The following is a description of a gene set: Human Gene Set: GOBP_RESPONSE_TO_METAL_ION studied in species Homo sapiens Any process that results in a change in state or activity of a cell or an organism (in terms of movement, secretion, enzyme production, gene expression, etc.) as a result of a metal ion stimulus., and this is the list of marker genes: DDX19A, ADAMTS13, CDKN1B, ATF4, B2M, ITPKA, CEBPA, G6PD, SLC39A8, FGA, CPNE1, TSPO, PPP2CA, MUC2, KCNMB2, SLC26A5, MYOG, HSF1, SLC25A39, LTA4H, RYR1, ATF1, ITPKB, SLC41A1, HVCN1, MDM2, INHBB, BRAF, CYP2R1, NPC1, GRIA1, FABP4, BGLAP, FXN, LCAT, CACNA1H, IL1A, CREB1, CPNE7, HCN1, PRKAA2, MICU2 (NCBI Gene Id 221154), D2HGDH, SLC12A2, ADGRV1, CER1, CLDN1, IMPA2, ENTPD6, HPCA, PKLR, CDK1, WNT5A, VPS54, TRPM2, AMELX, GIPR, TTN, SEC31A, ABCC8, CASP9, TNNC1 (troponin C1, slow skeletal and cardiac type), GABRB3, ATP7B, MT1A, SLC25A12, CDH1, ITPR3, CYP1A1, HNRNPD, FOSB, CASR, PRKN, HSP90B1, PDX1, CPNE8 (NCBI Gene Id 144402), TIGAR, ENDOG, KCNIP2, S100A16, PLCG2, NCSTN, GOT1, BECN1, BACE1, KCNA1, EIF2AK3, RASA4B, MAPK9, PPP3CA, MT1H, TAT, GPHN, CPNE3, TRPC3, MT1M, MT1F, CPNE2, UCP2, SLC30A10, MEF2C, CPNE6 (NCBI Gene Id 9362), MT1DP, JUNB, TLR9, PENK, SLC1A1, SLC30A4, ATP5F1D, PAM, RASGRP2, AANAT, XRCC4, SLFN14, NEK7, SLC30A2, ATP13A2, BCL2, NDRG1, CCND1, ADCY8, TRPC1, IQGAP1, TUBA1A, BMP6, AQP1, ABAT, S100A8, CYP11B1, TESMIN, ACER1, CYP1A2, JUND, AQP2, KMT2A, CNGA3, FECH, TFF1 (NCBI Gene Id 7031), ANK3, ATG5, MCOLN1, CRHBP, KCNMB4, RASAL1, PPP1CA, CRIP1, LONP1, ANXA7, SLC30A1, MAP1LC3A, ABCC9, NFATC2, HIF1A, KCNC1, PARK7, LCN2, PLSCR1, RYR3, SLC13A2, CAT, ATP7A, ASPH, SLC25A24, ADAM9, TERT, SHH, AKR1C3, LOXL2, PPP2CB, CASP8, PDCD6, CLIC4, GUCA1ANB-GUCA1A, EDN1, MT1G, SCN5A, SUMO1, LCN6, MNAT1, LIG4, PEF1, HESX1, LCE1D, KCNB1, MT4, MEF2A, KCNMA1, TCIRG1, CHP2, FGF23, PPIF, KIT, THBS1, CPA1, EIF2S1, CYBRD1, CYBB, NPTX1, PTH, MAPT, GSS, SLC30A5, CPOX, KCNK3, CPS1, CALR, TRPV6, HSD17B1, ALOX15, CACNA1G, MT3, GPI, PGAM2 (phosphoglycerate mutase 2), MTF1, GNRH1, PKD2, DAXX, CACNG2, SUCNR1, HAAO, PRNP, ITPKC, SLC6A3, LRRK2, ADD1, KCNQ3, SOD1, SLC13A5, NFE2L1, CASP3, ALAD, CASQ2, NFE2L2 (NCBI Gene Id 4780), CAMK2D, FBP1, KCNJ10, ADCY1, VCAM1, CAV1, GSK3A, ECT2 (epithelial cell transforming 2), PCNA, CPNE9, TNNT2, P2RX7 (NCBI Gene Id 5027), NEUROD2, HOMER1, GLRA1, TXNIP, FGG, EEF2K, RYR2 (NCBI Gene Id 6262), SOD2, MICU3, OTC, CACYBP, HFE, DLG2, KCNC2, TFAP2A, CPNE5, GDI1, SLC34A1, PRKAA1, MTTP, TFR2, LGMN, AQP3, HMGCS2, BSG, CPNE4 (NCBI Gene Id 8902), ABCC6, ZNF658, UROS, ALAS1, KCNMB1, ID2, ZACN, MT1X, SMPD3, ALOX5AP, GUCA1A, MT1B, NEDD4, MT1HL1, SNCA, STIM1, SLC11A2, BNIP3, NLGN1, MT-CYB, DRD2, FGB, CARF, KHK, CALM2, ASS1, STK39, TF, TFRC, MT-CO1, NFATC4 (NCBI Gene Id 4776), PARP1, SLC25A23 (solute carrier family 25 member 23), ABCB1, SYT1, CUTA, KCNH1, DPEP1, NRXN1, APP, SLC11A1 (solute carrier family 11 member 1), FOS, CALM1, CYP11B2 (cytochrome P450 family 11 subfamily B member 2), SERPINF1, KCNMB3, CAPN3, JUN, DNMT3A, MT1E, SLC25A13, HMOX1 (heme oxygenase 1), SETD2 (NCBI Gene Id 84184), SLC30A3, MT2A, P2RX5, PLN, GLRA2, ACO1, SMPD1, SLC30A8, DUSP1, GRXCR1, ABCB6, RASA4, MICU1, P2RX4, PPP5C, DLG4, ADCY7, GCLC, ATP1A2, ANXA11, AHCYL1, HAMP, CALM3, CCNB1